The following is a description of a gene set: Human Gene Set: GOBP_MAINTENANCE_OF_PROTEIN_LOCATION species: Homo sapiens Any process in which a protein is maintained in a location and prevented from moving elsewhere. These include sequestration, stabilization to prevent transport elsewhere and the active retrieval of proteins that do move away., and this is the list of marker genes: CHCHD10, CAV1 (NCBI Gene Id 857), PDIA2, TAF8, NRROS, LTBP1, KDELR2, NR5A1, ANK3, GOLPH3, SUN2, TAF3, PARK7, RER1, SUN1, INSIG2, ARL2, CD4, SORL1, VPS13A, SUPT7L, FBN2, AKT1, TOPORS, MICOS10-NBL1, SYNE1, CIZ1, NBL1, DAND5, GPAA1 (NCBI Gene Id 8733), KDELR3, CER1, SKP1, SP100, BBS4, SRGN, PINK1, PKP2, TMED2, CCDC88A, HK2, TXN, HNRNPU, HK1, RANGAP1, ANKRD13C, KDELR1, PGR, HSPA5, RIT2, CDK5, MDFI, INSIG1, FBN1, MORC3, FREY1, FKRP, HDAC3, OS9, VPS13C, TSPO, DBN1, ARL2BP, BARD1, VPS13D, PML, FAM76B